The following is a description of a gene set: from publication Cui A, Huang T, Li S, Ma A, Pérez JL, Sander C, Keskin DB, Wu CJ, Fraenkel E, Hacohen N (PMID 38057668) Genes positively differentially expressed in cell type: cDC2 (conventional dendritic cell type 2) upon treatment with cytokine: IL-33 in mouse lymph nodes in vivo. Mouse Gene Set: CUI_CDC2_IL33_RESPONSE_UP Cytokines mediate cell-cell communication in the immune system and represent important therapeutic targets. A myriad of studies have highlighted their central role in immune function, yet we lack a global view of the cellular responses of each immune cell type to each cytokine. To address this gap, the authors created the Immune Dictionary, a compendium of single-cell transcriptomic profiles of more than 17 immune cell types in response to each of 86 cytokines (>1,400 cytokine-cell type combinations) in mouse lymph nodes in vivo. A cytokine-centric view of the dictionary revealed that most cytokines induce highly cell-type-specific responses. For example, the inflammatory cytokine interleukin-1β induces distinct gene programmes in almost every cell type. A cell-type-centric view of the dictionary identified more than 66 cytokine-driven cellular polarization states across immune cell types, including previously uncharacterized states such as an interleukin-18-induced polyfunctional natural killer cell state. studied in species Mus musculus, and this is the list of marker genes: Ptpn1, Nrp2, Cdkn1a, Slc2a1, Ppp1r2, Ccr5 (C-C motif chemokine receptor 5), Ifi35, Cdh1, Ccl17, Ebf1, Cflar, Iqgap1, Zfp366, Clec4n, Rab1a, Srek1, Slc12a7, Eef1e1, Eif3a, Atp2c1, Malt1, Klf7, Gnb1, Eif4g2, Rap1a, Socs2, Nfkb1, Ccl12, Imp4, Ly6a, Ndufab1 (NADH:ubiquinone oxidoreductase subunit AB1), Actg1, B4galt5, Fnbp1l, Socs1, Tspo, Tarm1, Ngfr, Mrpl45, Cyp7b1, Arl8a, Eif5a, Rras2, Pdia4, Irf7, Cltc, Eif4a1, Zwint, Snrpa1, Sec23b, Ctsz, Uck2 (uridine-cytidine kinase 2), Psmb6, Arl8b, Riok3, Slfn2, Rara, Hnrnpk, Cst7, Niban2, Plpbp, Sh3pxd2b, Dok2, Erlin2, Slc15a3, Tnip3, Tmem167, Rab14, Cd164, Rap2a, Chchd4, Sf3b6, Pnp, BC031181, Rnf19b, Mat2a, Fyn, Aqp3, Sdc3, Cd53, Necap2, Pfn1 (profilin 1), Arpc2, Lgmn, Socs3, Psmd2, Nras, Flot1, Htr7, Pim1, Gbp7, Snx3, Gpr171 (NCBI Gene Id 229323), Myl12a, Efhd2, Wfdc17, AA467197, Snd1, Atp5pb, Hnrnpll (NCBI Gene Id 72692), Gtpbp4, Rigi, Snap23, Jak2, Naaa, Hsp90b1 (heat shock protein 90, beta (Grp94), member 1), Dse, Prkcd, Tns1, Ak2 (adenylate kinase 2), Syngr2, Fabp5, Polr1h, Slc30a4, Cish, Igkc, Ifi204, Orai1, Ddx39b, Tubb4b, Lair1, Hif1a, Septin3 (septin 3), Creld2, Il1rn, Tmbim1 (NCBI Gene Id 98587), Mrc1, Ruvbl1, Prkd3, Basp1, Wdr46, Aamp, Cd209e, Rap2c, Dnajb11, Sdc4, Kdr, Gramd4, Tuba4a, Psmd5 (NCBI Gene Id 99366), Usp24, Pdia3, Ogdh, Olfm1, Abce1, Eif4e, Hnrnpf, Snx2, Pdia6, Sumo2, Irf4, Foxn3, Fh1, Rab3il1, Cd274, Timm17a, Rcl1, Psme2, Calr, Emc4, Serpina3g (NCBI Gene Id 20715), Lcp1, Pcbp1, Eps8, Il4i1 (NCBI Gene Id 15088), Trio, Manf, Scimp, Klhdc4, Ppp1r11, Lrrk1, Xbp1, Prps1, Tuba1b, Kdm5c, Capzb, Ms4a6d, Ostc, Wdr1, Med8, Spi1 (Spi-1 proto-oncogene), Vasp, Adrm1, Cd40, Pacsin2, Smad2 (SMAD family member 2), Hbegf, Gtf3c6, Hspa9, Vrk1, Srsf2, Gpr183, Mif4gd, Hspa5 (heat shock protein 5), Adam8, Pfkp, Zc3h12c, Adam19, Gfra2, Pgs1, Srsf7, Psma3, Dynll1, Hspa8 (NCBI Gene Id 69197), Nr4a3, Casp6, Surf4